Given this list of marker genes ZIC4, PTGES2, SYNGAP1, POM121, DYNLL2, here is a description of the gene set: Genes having at least one occurence of the motif GGCGGCA in their 3' untranslated region. The motif represents putative target (that is, seed match) of human mature miRNA hsa-miR-371 (v7.1 miRBase). Human Gene Set: GGCGGCA_MIR371 species: Homo sapiens